Given this list of marker genes AGO2, AGO4 (argonaute RISC component 4), TNRC6B, AGO3, TNRC6C, TNRC6A, miR-224, MOV10, NPAS4, AGO1, here is a description of the gene set: Reactome Pathway: Regulation of NPAS4 mRNA translation The 3'UTR of NPAS4 mRNA is highly conserved between mouse, rat and human (>95% identity across ~700 bp of the 3'UTR sequence). Of the three putative microRNAs, miR-224, miR-203 and miR-132/212, that were predicted to target the 3'UTR of NPAS4 mRNA by multiple computational algorithms, miR-224 and miR-203 were able to significantly downregulate expression of the NPAS4 3’UTR reporter construct. Downregulation of Npas4 expression by miR-224 was also shown in mouse. Npas4 was also reported as a target gene of miR-1, miR-142 and miR-744. Only microRNAs that were reported to target Npas4 mRNA by at least two studies are shown in the diagram. The circulatory RNA circ_0003420 was also reported to target NPAS4 mRNA and contribute to its degradation. species: Homo sapiens part of: Regulation of NPAS4 gene expression